Given this list of marker genes SQSTM1, ATG5, WDFY3, ZDHHC19, LYPLA1, ATG4C, WDR81, ATG4A, ATG4D, BAG3, KAT5, ATG4B, HDAC6, HTT, UBQLN1, MAP1LC3C, HSPB8, CSNK2A1, here is a description of the gene set: studied in species Homo sapiens Human Gene Set: GOBP_AGGREPHAGY The selective degradation of protein aggregates by macroautophagy.